Given this list of marker genes St6galnac6, St6gal2, Slc17a5, St6galnac3, St6galnac2, St6gal1, St3gal4, Neu1, Gne, St8sia6, St3gal1, St8sia3, St8sia5, St6galnac4, St6galnac5, St8sia2, Nans, Neu3, Nanp, Neu2, Neu4, St3gal5, Slc35a1, Glb1, St3gal6, St8sia1, St3gal3, St6galnac1, Cmas, St3gal2, Ctsa, Npl, St8sia4, here is a description of the gene set: Mouse Gene Set: REACTOME_SIALIC_ACID_METABOLISM Sialic acid metabolism species: Mus musculus